Given this list of marker genes ENG, MAPK3, EDN1, FOLR1, TWIST1, CITED2 (NCBI Gene Id 154106), HES1, PITX2, CDC42, EDNRA, JAG1, HAND2, BMP4, SEMA3C, MAPK1, BMP7 (NCBI Gene Id 655), here is a description of the gene set: Human Gene Set: GOBP_CARDIAC_NEURAL_CREST_CELL_DIFFERENTIATION_INVOLVED_IN_HEART_DEVELOPMENT species: Homo sapiens The process in which a relatively unspecialized cell acquires specialized features of a cardiac neural crest cell that will migrate to the heart and contribute to its development. Cardiac neural crest cells are specialized cells that migrate toward the heart from the third, fourth and sixth pharyngeal arches.